Given this list of marker genes Rpl32l, Rpl36a, Mrpl20, Rpl41, Mrpl9, Mrpl36, Rpl39l, Rpl7a, Rpl10, Mrpl13, Uba52, Rpl9-ps1, Mrpl43, Mrpl48, Mrpl34, Rpl7, Rpl35a, Rpl6l, Mrpl53, Mrps30, Rpl35, Rpl17-ps8, Rbm3, Rpl23, Mrpl40, Mrpl46, Rps12 (ribosomal protein S12), Rpl35rt, mt-Rnr2 (mitochondrially encoded 16S rRNA), Mrpl22, Rpl17, Rpl5, Rpl26, Uba52rt, Gm6133 (NCBI Gene Id 676276), Mrpl42, Rpl4, Gadd45gip1, Mrpl1, Rpl34-ps2, Rpl14, Rpl18a, Rpl8, Rpl13, Mrpl41, Mterf4, Mrpl37, Rpl32, Rpl22, Mrpl49, Mrpl4, Rplp2, Rpl15, Nsun4, Rpl18, Rpl36al, Rpl27rt, Mrpl2 (mitochondrial ribosomal protein L2), Mrpl10, Rpl37rt, Mrpl16, Mrpl11, Mrpl35, Rpl13a, Rpl10-ps3, Rpl10a, Rpl37a, Gm6525, Rpl37, Mrpl23, Rpl32-ps, Mrps18a, Rpl12, Mrpl30, Mrpl52, Mrpl55, Rpl34, Mrpl44, Mrpl27, Mrpl18, Rpl21, Mrpl12, Mrpl21, Rpl6, Mrpl24, Rpl13-ps6, Mrpl15, Rplp1rt, Rpl3, Mrpl45, Rpl24, Nsun3, Rpl19, Rpl9-ps6, Mrpl57, Rpl31, Rplp2-ps1, Mrpl58, Mrpl50, Rpl3l, Rpl11, Mrpl19, Zcchc17, Mrpl39, Mrpl28, Rpl27a, Mpv17l2, Rpl38, Uba52-ps, Mrpl54, Mrpl47, Rplp0, Rpl34-ps1, Rplp1, Rpl27, Mrpl17, Rpl9, Rpl39, Mrpl38, Rpl23a, Rpl36, Rpl36-ps12, Rpl30, Mrpl51, Mrpl33, Mrpl32, Npm1, Rpl10l, Rpl28, Rpl29, Rpl7l1, Mrpl3, Mrpl14, here is a description of the gene set: Mouse Gene Set: GOCC_LARGE_RIBOSOMAL_SUBUNIT studied in species Mus musculus The larger of the two subunits of a ribosome. Two sites on the ribosomal large subunit are involved in translation, namely the aminoacyl site (A site) and peptidyl site (P site).